The following is a description of a gene set: species: Homo sapiens Genes down-regulated in the ANBL-6 cell line (multiple myeloma, MM) after withdrawal of IL6. Human Gene Set: CROONQUIST_IL6_DEPRIVATION_DN ANBL-6, a myeloma cell line, proliferates in response to interleukin 6 (IL-6) stimulation, coculture with bone marrow stromal cells, and when harboring a constitutively active mutant N-ras gene. Eighteen samples, including 4 IL-6-treated, 3 mutant N-ras-transfected, 3 normal stroma-stimulated, 2 multiple myeloma (MM) stroma-stimulated, and 6 untreated controls were profiled using microarrays interrogating genes. Global hierarchical clustering analysis distinguished at least 6 unique expression signatures. Notably, the different stimuli altered distinct functional gene programs. Class comparison analysis (P =.001) revealed genes (54% involved in cell cycle) that distinguished IL-6-stimulated versus nontreated samples. Eighty-seven genes distinguished stroma-stimulated versus IL-6-treated samples (22% encoded for extracellular matrix proteins). A total of genes distinguished N-ras transfectants versus IL-6-treated samples (26% involved in metabolism). A total of genes, 20% of these involved in signaling, distinguished N-ras from stroma-interacting samples. All 3 stimuli shared genes, mostly of metabolic function. Genes that distinguished MM1 from MM4 clinical groups were induced at least by one treatment. Notably, only genes (ETV5, DUSP6, and KIAA0735) are uniquely induced in mutant ras-containing cells. We have demonstrated gene expression patterns in myeloma cells that distinguish an intrinsic genetic transformation event and patterns derived from both soluble factors and cell contacts in the bone marrow microenvironment. from publication Croonquist PA, Linden MA, Zhao F, Van Ness BG (PMID 12791645), and this is the list of marker genes: TOP2A, MCM3, CCNF, AURKB, SPAG5, PCNA, FRZB, APOBEC3B, GALE, RFC3, ABHD5, CHAF1A, NCAPH, CKS2, CCNB1, HMMR (hyaluronan mediated motility receptor), PCLAF, GALK1 (galactokinase 1), GGH, RRP12, CCNB2, CDK1, SMC4 (NCBI Gene Id 10593), PTP4A3, PTTG1, GINS1, BUB1B, FANCI, MAD2L1, MKI67, KIF14, CDC6, KPNA2, TRAIP, H2BC11, FOXM1, MCM4, POLD1, CCNE2, STMN1 (stathmin 1), SPC25, AURKA, BUB1, SBNO2, CKS1B, PLK4, TPX2, ZWINT, KIF2C, SNRPA1, WEE1, GPX4, CDKN3, HMGB2, RRM2, TRIP13, SKP2, DTYMK, LIG1, SEPHS1, POLE2, MYBL2, MCM7, BRCA1, AASS, TK1, KIF22, KIFC1, ITM2A, CDC25A, SPP1, CDC45, CENPE, CCNA2, CENPA, KIF11, SPOUT1, GMPS, NASP, MYRF, OIP5, CDC20, KNTC1, ANP32E, TYMS, UBE2C, STIL, CHEK1, DHFR, PLK1, HMGA1 (high mobility group AT-hook 1), SMC2, DUT, PTPRC, MCM2